The following is a description of a gene set: Human Gene Set: GOBP_DETECTION_OF_STIMULUS species: Homo sapiens The series of events in which a stimulus is received by a cell or organism and converted into a molecular signal., and this is the list of marker genes: OR11L1, NR2F6, OR9A2, OR1A2, WHRN, NLRC4, CST2, OR10T2, TAS1R1, OR2J2, OR5K1, OR4D2, TAS2R16, GNGT2, OR13F1, CALM2, OR2L5, HLA-B, OR4Q2, PTK2, OR52P1, SCARB1, TAS2R50, OR5P3, OR6N1, OR2T33, ELOVL4, PRDM12, WDR47, OR1J2, OR5AS1, PNPLA2, OR52N2, NTRK1, OR52N4, OR1N2, UNC119, OR1M1, OR4D11, OR6F1, OR52R1, OR7E24 (NCBI Gene Id 26648), OR4F15, OR4K15, OR5L2, OR8B2, OR4K13, OR6B1, OR2T6, OR4M1, OR56B2P, OR8B12, OR2L13, OR6C76, RTP5, OR10K2, OR10C1, CABP4, COL11A1, OR5AK2, OR51A2, TRPC3, OR4F16, CAV3, RRH, LPO, PRPH2, OR8K3, PKD2L2 (polycystin 2 like 2, transient receptor potential cation channel), PKD2L1, OR2J1, OR2A25, OR4D10, OR10R2, ENG, OR4C15, OR6B3, PDE6C, SAG, NR4A1, CST4, OR5L1, OR7C1, OR4K5, OPN3, CYB5R4, SSC5D, OR4A15, OR4F3, OR2A12, OR2L3, OR4C45, OR10D3, OR11H4, OR4F5, OR5B21 (NCBI Gene Id 282778), HPN, SRPX (sushi repeat containing protein X-linked), OR2W3, REST, OR52N1, PKD1L2, OR6M1, OR10G7, TRPV1, GUCA1B, OR52H1, OR10Z1, TAS2R42, RTP3, OR8K5, OR10H4, PECAM1, OR52E6 (NCBI Gene Id 81265), TAS2R46, OR1S2, OR2A5 (olfactory receptor family 2 subfamily A member 5), OR5D13, PLCB2, TAS1R2, OR14K1 (NCBI Gene Id 81452), OR51B2, PKDREJ, OR1J1, OR9G1, CALM1, OR11H2, OR10G2, HLA-A, TSPO, PGLYRP4, OR2A7, OR2T27, OR1D2, ROM1, OPN1MW3, OR8S1, TAS2R41 (NCBI Gene Id 259287), OR1L3, CASQ2, OR13C8, OR2Y1, MYC, OR6V1, OR1B1, C4B, ADORA1, OR2H2, OR1F2P (NCBI Gene Id 26745, olfactory receptor family 1 subfamily F member 2 pseudogene), RHO, OR7A5, PPEF1, OR4C16, OR4A47, TAS2R10, OR56A4, OR13C5, PIEZO1, OR2AP1, OR5D16, OR1G1, OR13J1, OPN1MW2, KCNK4, OR56A3, OR2AG2, OR5M10, OR11H7, OR52A4P, LXN, OR6Q1, OR10A2, OR7A2P, CCDC66, OR8D2, SCN9A, TTN, KCNMB4, ATP8A2, OR5H2, GUCY2F, OR1L4, LBP (lipopolysaccharide binding protein), OR5F1, KCNMB3, OR5M3 (NCBI Gene Id 79520), OR2D3 (NCBI Gene Id 81334), OR14L1, OR10AC1, OR1N1, TREM2, GRK1, TTR, OR52N5, OR4M2, OR8J1, OR4F29, OR5T3, OR7C2, OR52E8, TLR2, DRGX, OR2D2, SYT1, OR10J6P, OR1P1, SCRN3, OTOP1, OR1D4, OR8H2, OR3A2, TAS2R31, PDC, OR14A16, OR7G2 (olfactory receptor family 7 subfamily G member 2), OR13C4, PAK1, OR10G8, OR6P1, OR56A5, OR1J4, OR52L1, PPEF2, OR7D2, CACNA1F, OR2B3 (NCBI Gene Id 442184), OR4N4, OR2F1, OR13C6P, OR52E4, PHF24, PIEZO2, OR1L6, TAS1R3 (NCBI Gene Id 83756), OR8G2P, RTP4, KIT, KCNA1, OR2T3, OR10A5, OR11G2, SEMA5B, TAS2R8, OR4F17, MMP24, OR4L1, PITPNM1, OR6B2, PDE6B (NCBI Gene Id 5158), OR4D9, GRK4, OR2B8P, OR52A5, OR10AG1, OR10W1, OR8U3, OPN1SW, OR6C1, P2RX2, TRPA1, ITGA2, HTR2A, OR51M1, OR7A17, OR7A10, OR2T4, OR5M8 (olfactory receptor family 5 subfamily M member 8), OR5A1, OR6K6, OR51G2, OR1S1, REG3A, OR7G3, OR13A1, OR6C75, TAC1, OR51A4, OR1L8, PKD1L1, OR51V1, OR52I2 (NCBI Gene Id 81259), OR4K2, TAS2R1, OR52B4, OR2A14, OR5K3, OR11H1, TAS2R43, TAS2R3, OR13C9, OR2T2, CAMKMT, OR6C68, OR10J4, EXTL3, OR1F12P, OR14I1, OR52B6, OR2T8, OR2F2, CHRNA10, OR2B6, KCNMB1, OR10J3, TAS2R9, OR51B6, OR8B8, OR10A7, OR10A6, OR51L1 (NCBI Gene Id 79303), CALM3, OR13C2, GUCY2D, CDH2, OR1C1, FFAR4, OR4X2, OR5G3, OR10AD1, ANO3, CSRP3, OR2G3, TAS2R5, OR4C5, OR51I2, SLC24A4, CXCL12, OR1D5, OR2T11, OR51C1P (olfactory receptor family 51 subfamily C member 1 pseudogene), OR4D1, OR10D4P, OR10P1, OR52E1, OR6C65, RCVRN, OR11H6, OR2M7, OR8I2, CDHR2, SCN11A, TLR4, KCNK3, OR4A16, OR51Q1, OR8D4, TCAP, OR5H14, LRIT1, OR4K3, STRC, SERPINE2, OR8U9, OR5H6, TAS2R38, HLA-DRB1, OR10H5, OR51E1 (olfactory receptor family 51 subfamily E member 1), OR5A2, OR56A1, OR5D14, OR2V2, OR52K2 (NCBI Gene Id 81257), PGLYRP2, OR10S1 (NCBI Gene Id 79519), GPR148, OR4F4, OR5D18, OR3A1, OR2AJ1, GNAT2, TMEM120A, OR9A1P, OR2AE1, TAC4, OR4D6, CD1D, OR3A3, OR2AT4, OR56B1, OR10G6 (NCBI Gene Id 79490), OR5T2, OR5B2, OR51F1, OR5J2, OR52K1, OR4E1, TNF, OR10K1 (olfactory receptor family 10 subfamily K member 1), PKD1, OR4K14, OR52E5, OR5AL1, OR52B2, OR2C3, OR8J2, FAP, OR2M4, PGLYRP3, LY96 (NCBI Gene Id 23643), OR5C1, OR2M5, OR5B12, OR5I1, ASIC2 (acid sensing ion channel subunit 2), FECH (NCBI Gene Id 2235), RP1, GRM6, OR52E2, SMO, OR6K3, OR10Q1, OR2M3, PKD1L3, OR4P4, ADGRV1, OPN1MW, TAS2R14, ASIC3, OR8G3P, OR11H12, OR52J3, OR6C70, OR4K17, TAS2R4, OR5AR1, COMT, OR2W1, CTNNB1, OR56B4, OR4C11, OR6C74, PIP (prolactin induced protein), OR2M2, OR4A5, OR52I1, OR51D1, NOD1, OR2T29, OR51H1, AIPL1, NAIP, MKKS, CA6, OR8U1, GRIK2 (glutamate ionotropic receptor kainate type subunit 2), OR8H1, OR1E1, OR1E2, CLEC7A, ABCA4, OR11A1, CNGB1, CRB1, CLEC6A, TAS2R13, OR6C3 (olfactory receptor family 6 subfamily C member 3), RTP2, OR2T5, OR51S1, SOD2, TACR1, OR8B3, OR13C7, OR51T1 (NCBI Gene Id 81275), OR13G1, OR5M1, GUCA1A, OR51B4, OR8A1, DISC1, GPR88, OR51J1, OR2T7, FYN, FOXF1, OR10J5, PTPRJ, OR4B1, OR5B3, OR2A2, CST1, PDZD7, OR8G5, PKD2, OR8G1 (olfactory receptor family 8 subfamily G member 1), OR2Z1, PCP2, OPN1LW, GRK7, BACE1, OR1F1, PTPRQ, OR2B2, GNAT1, NTSR1, OR5K2, TAS2R45, OR9I1, OR2T34, OR9G4, OR2A4, OR5AC2, OR5K4, OR10A4, SLC11A2, OR5H15, OR1Q1, OR6K2, GUCA1ANB-GUCA1A, OR5B17, RGS9BP, CACNB4, SCN1A, OR12D1, OR6C4, TAS2R40, OR2T12, TGFB3, OR10G4, OR6J1, OR13D1, OR2V1, OR10H2, CHRNA9, TAS2R20, TULP1, OR9A4, TLR1 (NCBI Gene Id 7887), OR2T35, KCNK2, OR2S2, OR5H1, OR5BS1P, OR2T1, OR9Q2, NPFFR2 (neuropeptide FF receptor 2), OR4C6, OR10G9, TAS2R19 (taste 2 receptor member 19), OR4S2, OR51B5, OR10G3, OR2J3, LHFPL5, OR2W5P, GPR52, OR2C1, NOX3, OR5M9, OR7D4, STIM1, OR4K1, OR4C3, OR5T1, OR2B11, OR52A1, PLEKHB1, OR6T1, OR51E2, OR8U8, OR12D3, OR52W1, OR52L2P, OR5M11, TLR6, OR2W6P, OR10H3, RYR2, OR12D2, OR8H3, OR5W2, GNAT3, OR2L2, KCNIP2, NMT1, NLRP3, SLC24A2, OR4N2, OR1A1, OR51I1, OR6X1, OR2G6, OR52M1 (olfactory receptor family 52 subfamily M member 1), OR2K2, OR51F2, DACH1, OR14J1 (NCBI Gene Id 81700), OPN5, RPE65 (retinoid isomerohydrolase RPE65), OR6C2, TAS2R7, KCNMB2, OR2G2, RTP1, CEP250, PIGR, OR8K1, OR10X1, OR4C13, CACNA2D4, GNA11, OR10A3, OR5AK3P, OR5AU1, OR4E2, TIMELESS, TMEM87A, OR2H1, TLR9 (NCBI Gene Id 54106), OR1L1, OR9K2, OR4M2B, CADM1, NGFR, GNGT1, OR4F6, OR2I1P, OR13C3, ANO1, OR6C6, OR2AG1, OR5V1, TMC1, OR13H1, JUP, OR4A4P, OR51A7, PGLYRP1, OR8J3, ASPH, OR5AC1, NR2E3, NOD2, NMT2, OR5AN1, OR52Z1P, OPN4 (opsin 4), BEST1, OR6N2, OR2L8, EYS, OR9G9, OR6S1, OR4X1, OR14A2, RBP4, OR8B4 (NCBI Gene Id 283162), OR2A42, OR4N5, CASR, OR9Q1, EPHB1, GNAQ, AZGP1, OR5P2, PJVK, OR4S1, ATF2, TAS2R30 (taste 2 receptor member 30), GJA10, RGR, OR2AK2, OR6A2, CDS1, OR10J1, OR1K1, OR4Q3, OR4C12, REEP6, OR4F21, CRTAM, OR8D1, OR14C36, OR4C46, OR10V1, OR5H8, TAS2R39, OR1I1, TAS2R60, OR10H1, OR5AP2, OR52D1, OR51G1, OR4D5, OR7G1, OR4A8, KCNQ1, OR6Y1, OR2T10, OR1E3, OR2A1, TMC2